The following is a description of a gene set: species: Homo sapiens Human Gene Set: MIR450B_3P Genes predicted to be targets of miRBase v22 microRNA hsa-miR-450b-3p in miRDB v6.0 with MirTarget v4 prediction scores > 80 (high confidence targets). from publication Chen Y, Wang X (PMID 31504780), and this is the list of marker genes: C4orf19, HMCN1, DPY19L4, SP8, MACF1, IKZF1, RFC3, DCLRE1C, HEY2, ZNF708, KDSR, C5orf15, KLF7, EYS, PGK1, GPR180, TPBGL, KDM4C, PIP5K1A, WBP1L, TMED2, ILDR2, TMEM139, ASAP1, CCDC92, CBLN2, DACT1, SFRP5, ZSWIM9, GABRG2, NECTIN2, NSFL1C, GALNT10, PEG10, C11orf58, PBXIP1, AP3S1, KRTAP17-1, PTPN11, LMBR1L, POLQ, C6orf136, NOVA1, SP7, HSP90B1, SLC25A23